Given this list of marker genes Kdm4c, Rab21, Slc39a8, Cpeb4, Cltc, Otx2, Znhit6, Iglon5, Cdk17, Pou3f2, Zfp711, Arglu1, Fam184b, Klhl15, Glrb, Sirt1, Srsf7, Ro60, Ndfip2, Mbnl1, Caprin1, Ifi44, Cxadr, Zfp148, Syde2, Cpeb2, Erg, Wdr76, Zfp800, Camk2d, Pfn2, Slc25a53, Cdk19, Agfg1, Septin10, Fbrsl1, Agbl3, Ttc28, Nrg3, Chd9, App, Ubqln1, Cntn3 (contactin 3), Pkn2, Kcnb2, Pank3, Agap1, Glcci1, Ednrb, Fkrp, Galnt7, Dicer1, Stk4, Mapre2, Atg3, Map3k8, Adamtsl3, Zfp819, Slc5a7, Abi1, Ccdc169, Tvp23a, Clasp2, Irgm2, Pou3f3, Serp1, Sowahc, Baz2a, Elf2, Zdhhc21, Mindy2, Sacm1l, Gabrb3, Steap2, Mbtps1, Dact1, Cadm2, Crppa, Smc2, Elavl4, Smarca1, AI593442, Tbc1d30, Nrip1 (NCBI Gene Id 77882), Smim13, Fzd10, Rnf6, Frk, Ulk1, Mapk1, Chrdl1, Eif4e, Sp3, Nalf1, Sri, Cd8a, Fbxo43, Wnk3, Tmem45a, Rock1, Gabra6, Cep170, Asxl3 (NCBI Gene Id 399610), Rhobtb3, Thsd7a, Mfsd6, Srpk2, Zfp760, Lipg, Mfap3l, Dr1, Trim8 (NCBI Gene Id 93679), Csf3, Rag1, Rgs4, Slc28a3, Wsb1, Kpna3, Fam120a (NCBI Gene Id 218236), Smarca5, H2-Eb2, Ajap1, Zdhhc15, Trmt2a, Slc35f4, Spink5, Dmc1 (NCBI Gene Id 13404), Tm6sf1, Tdrd3, Kctd6, Brd10, Ubxn4, Guf1 (GUF1 homolog, GTPase), Hif1a, Rbmxl2, Prokr2, Slc25a32, Phactr2, Gpr158, Speer4b, Magi1, Scn4b, Ipo5, Atp11a, Nwd1, Naalad2, Tcim, Apobec3, Dhx57, Xirp2, Grhl3, Npy1r, Far1 (NCBI Gene Id 72904), Ube2a, Sec62, Ireb2, Frs2, Gucy2f, Sox11, Cfap418, Stx12, Hipk3, Pparg, Car8, Ric8b, Med13, Ildr2, Cntn4, Onecut2, Uts2b, Grb10, Cox15, Jph3, Tpgs2, Elmod1, Mmgt1, Trp53inp1, Mier1, Tnfsf15, Pclo, Azi2, Prrg1, Rusf1, Hook3, here is a description of the gene set: from publication Chen Y, Wang X (PMID 31504780) Genes predicted to be targets of miRBase v22 microRNA mmu_miR_669k_3p in miRDB v6.0 with MirTarget v4 prediction scores > 80 (high confidence targets). species: Mus musculus Mouse Gene Set: MIR_669K_3P